Given this list of marker genes Emc8, Rad23a, Acadl, Pml, Twf2, Erp29, here is a description of the gene set: Cytokines mediate cell-cell communication in the immune system and represent important therapeutic targets. A myriad of studies have highlighted their central role in immune function, yet we lack a global view of the cellular responses of each immune cell type to each cytokine. To address this gap, the authors created the Immune Dictionary, a compendium of single-cell transcriptomic profiles of more than 17 immune cell types in response to each of 86 cytokines (>1,400 cytokine-cell type combinations) in mouse lymph nodes in vivo. A cytokine-centric view of the dictionary revealed that most cytokines induce highly cell-type-specific responses. For example, the inflammatory cytokine interleukin-1β induces distinct gene programmes in almost every cell type. A cell-type-centric view of the dictionary identified more than 66 cytokine-driven cellular polarization states across immune cell types, including previously uncharacterized states such as an interleukin-18-induced polyfunctional natural killer cell state. Genes positively differentially expressed in cell type: cDC1 (conventional dendritic cell type 1) upon treatment with cytokine: Leptin in mouse lymph nodes in vivo. Mouse Gene Set: CUI_CDC1_LEPTIN_RESPONSE_UP from publication Cui A, Huang T, Li S, Ma A, Pérez JL, Sander C, Keskin DB, Wu CJ, Fraenkel E, Hacohen N (PMID 38057668) species: Mus musculus